The following is a description of a gene set: Mouse Gene Set: GOBP_REGULATION_OF_MEMBRANE_PERMEABILITY Any process that modulates the frequency, rate or extent of the passage or uptake of molecules by a membrane. studied in species Mus musculus, and this is the list of marker genes: Rhot1, Jam3, Tjp2, Cnp, Slc25a31, Mpv17l, Slc25a5, Alkbh7, Stpg1, Heg1, Chchd10, Bcl2l1, Bloc1s2, Slc25a4, Vdac2, Bok, Bax, Them4, Tmem102, Slc9a1, Fzd9 (frizzled class receptor 9), Atp5if1, Bcl2l11, Zfp13, Tmem14a, Bad, Dynlt1b, Hk2, Ppm1k, Lbp, Hip1r, Acaa2, Dynlt1a, Dynlt1f, Bnip3 (NCBI Gene Id 12176), Cldn3, Gimap3 (NCBI Gene Id 83408), Mtor, Nol3, Eya2, Pmaip1, Tmigd1, Gsk3a, Trp53, Spg7 (NCBI Gene Id 57358), Ier3, Fxn, Rasip1, Erbb2, Mtch2, Gimap5, F11r, Siva1, Bak1, Bnip3l, Erbb3, Camk2a, Rhot2, Bcl2l2, Laptm4b, Hspa8 (heat shock protein 8), Pdcd6ip, Mir874, Naif1, Laptm5, Slc35f6, Gsk3b, Nrg1, Gclc, Bcl2, Atf2, Ppif, Bid, Mul1, Stat3 (signal transducer and activator of transcription 3), Dynlt1c, Mylk3